Given this list of marker genes MSTN, FGF19, FGF11, FGF21, TNFSF15, LY6E, IFNL2, EPHA7, IL32, TNFSF12, ECRG4, CCL5, GFRAL, CRH, WNT3, IL4, MSMP, FGF16, CGB1, NPPB, BMP8A, APP, FAM3B, IL27, WNT2B, DKK1, GAST, NTS, LTBP1, FGF22, TGFB1, CCL4, CD48, FAM3D, CCL26, SEMA6B, GH1, CCL17, IL2, TGFB2, EDA, PNOC, VEGFA, APOA1 (apolipoprotein A1), XCL1, IFNA21, DEFB4A, CRLF1, WNT1, DEFB130B, GDF15, GALP, PRRT1, F2, PYY3, CCL4L2, SPP1, BMP15, CHGB, ULBP1 (UL16 binding protein 1), NRG1, IFNA6, PRKCE, PTK2B, IL20, UCN2, CXCL12, DEFB133, WFIKKN2, EPGN, SEMA3E, SEMA3F (NCBI Gene Id 7868), CXCL2, PPBP, PCSK9, DEFB104A, TG, IL24, PTHLH, IL31, CCL2, MDK, LY6G6D, TSLP, SLURP1, GUCA2A, NCR3LG1, IL11, IGFBP2, IL36RN, TMEFF1 (NCBI Gene Id 8577), HBEGF, SLURP2, NRG2, HMGB2, EGF, WNT9B, PDGFC, POMC, PRLH, WNT8A, LEP, FSHB, FGF3, BGLAP, CLEC12B, SEMA5A, TNFSF13B, MLN, OSTN, INHA, CCK, IFNK, C17orf99, IL18BP, TAC4, LYPD6 (LY6/PLAUR domain containing 6), SRC, LEFTY2, WNT4 (Wnt family member 4), CCL3L3, IFNA14, CXCL1, FGF4, LIF, SEMA3G, FNDC5, MRAP2, PENK, IL15, IL17C, HMGB1, PPY, GDF1, CCL20, DKK2, CCL19, CCL25, GHRH, INSL3, NPFF, IFNL1, EREG, BMP2 (NCBI Gene Id 650), IL22 (interleukin 22), PVR, FBN1, PYY, SEMA4B, CTF1, IFNL4, STC2, SEMA3B, CD40LG, DEFB114 (defensin beta 114), OXT, GPNMB, IFNA5, UCN, TAFA5, ANGPTL3, IL1A, FGF14, ALKAL2, ADM2, CSF3, LY6S, FBN2, ADIPOQ, IFNB1, OSGIN2, GDF5, IL7, JAK2 (Janus kinase 2), DPP4, MANF (mesencephalic astrocyte derived neurotrophic factor), MIF, IL17A, PGF, INHBE, VEGFD, IFNG, ANGPT1, FGF1, OSM, CORT, LYPD6B, REG1A, CSF1, CCL13, FGF7, CCN6, FGF2 (fibroblast growth factor 2), BAG6, CMTM7 (NCBI Gene Id 112616), IL17F, IGF1 (NCBI Gene Id 3479), WNT9A, DEFB103A, SFRP2, IFNA2, P2RY1, ENHO, NOG, LYPD1, IL13, NPPA, APOE, BMP7, GREM2, INHBB, GNRH2, IL36G, TNFRSF11B, IFNA17, INSL6 (NCBI Gene Id 82352), MIA, IFNA7, CRIPTO3, S100A4, IL25, REG3A, SEMA4F, RLN1, LGALS3, INS-IGF2, NENF, EBI3, C1QTNF9, JAG2, SST, IL9, METRNL, RLN3, CXCL5, COLEC10, BMP10, NAMPT, CLU, NPY, TAFA3, AREG, LYNX1, CTSG, PF4, GCG, WNT8B, TRH, DEFB103B, CALCB, IL23A, SEMA4C, TNFSF14, CSH1, WNT7A, LILRB4, CLEC11A, SPX, CCL7, PROK1, CGB2, WNT5A (Wnt family member 5A), CMTM5, CCL21 (NCBI Gene Id 6366), CSPG5 (NCBI Gene Id 10675), GRP, DLL4, OGN, TNFSF10, GIP, SPDYE11, CCL28, IFNA10, VIP, FST, ERFE, PSPN, STC1, IL33, TOR2A, PDGFB, CSH2, CLEC2B, RABEP2, CXCL3, SEMA7A, XCL2, PATE4, AVP, IL3, IL1RN, GDF7, NODAL, METRN, TTR, GDF3, DKK3, MRAP, CSF2 (colony stimulating factor 2), CGA, IGFBP7, CD86, BMP6, HDGF, IFNE, IFNA16, CXCL9, PSCA, SECTM1, RLN2, CMTM8, PDYN, IGF2, CCL14, DGKQ, CXCL6, IFNL3, CDNF, DKKL1, CD70, C7orf50, CCL8, FGF18, GDF9, DEFB110, GKN1, GDF2, RABEP1, SEMA6A, FGF17, CXCL16, GHRL, WNT2, HAMP, DUT, TAFA2, PF4V1, GDF10, INHBA, WNT10A, APOA2, UCHL1, CCL23, RETN, CMTM1, CMTM3, BMP8B, IGFBP5, DLL1 (NCBI Gene Id 28514), LTB, HCRT, CCL27, JAG1, IL6, TNFSF9, PMCHL2, FGF10, ADM, GREM1, CSHL1, TMEM35A, CKLF, ADA2, LY6H, PTN, GMFB, TSHB, AMBN, RETNLB, PRL, DEFB130A (NCBI Gene Id 245940), APELA, IL12A, CALCA, TAC1, LRRC32, INSL4, LEFTY1, ITPRIPL1, SCGB3A1, BMP3, CCL22 (NCBI Gene Id 6367), UTS2, C1QTNF12, DKK4, GAS6, GAL, PARK7, PATE1, CMTM2, ADH7, PDGFD, NPPC, C5 (complement C5), VGF, NTF4, NRG3, GPHA2, CLCF1, SEMA4D, MICOS10-NBL1, VSTM1, F2RL2, IGSF1, KNG1, TAFA4, CCL15, FGF6, FAM3C, SEMA3C, SCT, TNFRSF14, ENG, FLT3LG, CXCL10, IAPP, DEFB104B, AGT, CD80, NMB, CXCL13 (NCBI Gene Id 115545), WNT5B, FN1, UTS2B, AMELX, UCN3, FLRT2, CD274, PDGFA, CDK5, CCL18, NXNL1, CRIPTO, IZUMO1, TFF1 (trefoil factor 1), PMCH, ALKBH1, ANGPT4 (angiopoietin 4), LHB, IL16, GFER, CGB7, TGFA, APLN, AGRP, IL34, CXCL8, ULBP2, AIMP1, IL17D, TNFSF8, IL1B, FKBP1A, FGF12, TYMP, SEMA3A, THNSL2, CGB3, EDN1, SEMA4G, ANGPT2, OSGIN1, EFEMP1, GPR15LG, IL37, IFNA1, INHBC, IL10, NECTIN4, ADCYAP1, SEMA6D, WNT11, QRFP, ASIP, C1QTNF4 (C1q and TNF related 4), EDN2, FGF9, HSP90AB1, DEFB109B, IFNW1, MICA, FGF5, CXCL11, NRROS, NBL1, GDF11, BMP1 (bone morphogenetic protein 1), NRG4, IL21, LYN, WNT6, ALKAL1, FGF20, CCL1, CD320, TNFSF13, ICOSLG, BDNF, TNFSF4, FGF13, FLRT3, MMRN2, CCL3, GDF6, FGF8, GDNF, IL26, LAMA5, ZP3, ARTN, VEGFB, IL17B, CNTF, IL12B, ANG, APOB, IFNA4, CLEC12A, IL19, INS, CARTPT, GH2, GPHB5, NRTN, CCL16, LGALS9, NECTIN2, WNT7B (Wnt family member 7B), SEMA5B, TNFSF18, COPA, IL1F10, CCN3, RELN, PDE4D, VEGFC, AMH, CX3CL1, SCG2 (secretogranin II), HDGFL3, NGF, THPO, IL5, FGF23, MACC1, TGFB3, TAFA1, NPVF, DAND5, SEMA4A, BMP5, FASLG, AGTR2, EPO, BTC, SHH, INSL5, WNT16, GNRH1, TNF, CCL24, TNFSF11, GPI, EDN3, CCL11, LGALS1, KL, GRN, WNT10B (NCBI Gene Id 82499), LRPAP1, PTH (NCBI Gene Id 5741), THBS4, SEMA6C, CER1, PXDN, KITLG, IFNA8, ENDOU, IL36A, HSPA1A, IL18, WNT3A, TIMP1, HSPA8, SEMA3D, NDP, BMP4, IL36B, HGF, WFIKKN1, CXCL14, GMFG, CDC42EP2, C3, LTA, NTF3, PGLYRP1, LACRT, ESR2, ANGPTL8, EFNA5, HLA-E, here is a description of the gene set: Binds to and modulates the activity of a receptor. studied in species Homo sapiens Human Gene Set: GOMF_SIGNALING_RECEPTOR_REGULATOR_ACTIVITY